Given this list of marker genes ASAH1, ACER3, ACER2, GBA1, SPTLC2, SPHK1, ASAH2, AGK, SPHK2 (sphingosine kinase 2), ACER1, SPTSSB, SPTLC1, SPTLC3, SPTSSA, ABCA2, here is a description of the gene set: studied in species Homo sapiens The chemical reactions and pathways resulting in the formation of sphingoids, any of a class of compounds comprising sphinganine and its homologues and stereoisomers, and derivatives of these compounds. Human Gene Set: GOBP_SPHINGOID_BIOSYNTHETIC_PROCESS